The following is a description of a gene set: Mouse Gene Set: GOBP_REGULATION_OF_TRANSMEMBRANE_TRANSPORT Any process that modulates the frequency, rate or extent of the directed movement of a solute from one side of a membrane to the other. studied in species Mus musculus, and this is the list of marker genes: Fyn, Esr1, Lrrc26, Sphk2, Lhcgr, Prnp, Park7, Afg3l2, Rasa1, Asic2, Acsl6, Selenon, Stac, Dbi, Ffar4, Bin1, Dpp10, Akap7 (A kinase anchor protein 7), P2rx7, Gpc3, Oaz1, Ins2, Cnih2, Calm1, Sri, Ocln, Kcnj2, F2rl3, Grin2a, Grp, Rnasel, Grm6, Pou4f2, Gnb2, Mapk14, Ywhae, Kcnip2, Trdn, Trpc3, Cers1, G6pdx, Kcne3, Cyba, Homer1, Gsk3a, Rhoq (NCBI Gene Id 80836), Mrln, Kcnc2, Ptk2b, Mef2a, Mapk8ip2, Zfas1, Tmem74, Rgs7, Car2, Cacng7, Ucp2, Igf1, Kcnj6, Akap5, Ikbkb, Cacng3, Bpifa5, Nherf1, Kcnc1, Slc25a27, Nedd4, Chrm3, Fmr1, Tescl, Slc36a2, Trib3, Cd4, Sh2b2, Casq2, Fxyd4, Tlr9 (NCBI Gene Id 81897), Kcnab2, Plcg2, Scn4b, Coro1a, Braf, Fxyd5, Ywhah, Adipor2, Crhbp (corticotropin releasing hormone binding protein), Rem1, Agrn, Kcnn4, Fhl1, Atp4a, Prrt1 (proline-rich transmembrane protein 1), Camk2d, Rgs9, Actn2, Ctss, Enpp1, Cxcl9, Gpr39, P2rx1, Arg1, Nlgn1, Scn1b, Actb, Dysf, Atp4b, Gsto1, Hrc (NCBI Gene Id 15464), Ripk1, Cacnb4, Arg2, Septin2, Prkcd, Sumo1, Ppp3r1, Pim1, Drd2, Chd7, Cacnb2 (calcium channel, voltage-dependent, beta 2 subunit), Fgf15, Itln1 (NCBI Gene Id 640587), Wnk2, Ptpn3, Cacna1f, Casq1 (NCBI Gene Id 12372), Capn10, Edn1, Hspa2, Slc7a5, Shisa9 (NCBI Gene Id 72555), Wnk1, Bax, Adcyap1r1, Cemip, Cacng8, Abcb1b, Itgb3, Lep, Drd4, Ms4a2, Stim1, 1810037I17Rik, Plcb1, Shank1, Thbs1, Ffar1, Pea15a, Yes1, Ednra, Crh, Cox17, Cacng5, Repin1, Jsrp1, Slmap, Met, Nppa, Sorbs1, Gpr35, Kcnj16, Rap1a, Akt1, Fabp5, Edn3, Hap1, Lrrc52, Dmd, Ifng, Rps6kb1, Nol3, Jph3, Psen2, Cav1, Atp1b3, Arl6ip5, Tmc1, Ndufa4, Htt, Tgfb1, Kcnj10, Kcng4, Adrb1, Sestd1, Drd1, Cacna1c (NCBI Gene Id 619317), Irs1, Hamp2 (NCBI Gene Id 66438), Gnb5, Nedd4l, Clip3, Ahi1, Hk2, Cacng2, Fxyd6, Acsl5, Amigo1, Slc9a6, Epo, Erbb4, Akap6, Ywhaq, Chp1, Bmp4, Ntsr1, Cd19, Lcn2, C3, Ppp3cb, Ahr, Pik3cg, Oxsr1, Gimap5, Kel, F2r, Oprm1, Kcng1, Kcnj11, Taco1, Erfe, Thy1, Gip, Kcnmb1, Ubqln1, Gjc2, Arhgef11, Fxyd7, Tcaf1, Kcnn2 (NCBI Gene Id 14301), Sln, Kcns1, Ptpn22, Stxbp4, Tmem38a (transmembrane protein 38A), Prkca, Itgb1, Slc8a1, Cacng4, Myo5a (myosin VA), Ano6, Rgs4, Kcnj12, Ace, Stk39, Tcirg1, Dpp6, Cav3 (NCBI Gene Id 12391), Prss8 (NCBI Gene Id 97375), Fkbp1a, Appl1, Galr2, Ubr3, Arf1, Slc43a1, Cracr2a, Kcnj15, Nr4a3, Opn3, Abl1, Appl2, Pcsk9, Ppif, Kcnab3, Iscu, Gpd1l, Fkbp1b, Klf15, Il4 (NCBI Gene Id 16189), Atp2b4, Kcnip1, Kcnrg, Capn3, Gimap3, Rtn2, Atp2a1, Npsr1, Cbarp, Prkci, Rangrf, Bpifa1, P2ry6, Smim43, Cx3cl1, Mettl21c, Smim6, Tmc2, Osbpl8, Nlgn3, Arl6ip1, Upk3b, Kcnj3, Il1b, Stimate, Stxbp3, Rnf207, Gria1, Kcng3, Atg5, Abcc9, Cxcl11, Hpca, Pik3c2a, Atp1b2 (ATPase, Na+/K+ transporting, beta 2 polypeptide), Irs2, Tert, Tspan13, Ubash3b, Cacnb1, Prkd1, Pirt, Oaz3, P2rx4, Ldc1 (NCBI Gene Id 332942), Per2, Dlg1, Cacna2d1, Ms4a1, Kcnab1, Lime1, Ace2, Sirt6, Gal, Rgs2, Slc43a2, Erbb3, Lrrc55, Kcne2, Pln (NCBI Gene Id 18821), Cacna1d, Slc30a1, Ppp3r2, Kcnj1, Jph2, Gper1, Prkce, Tmem38b, Rasgrf1, Kcnip4, Crebl2 (cAMP responsive element binding protein-like 2), Shisa7 (NCBI Gene Id 232813), Grin2c, Nipsnap2, Oaz2, Akt2, Nfe2l2, Atp7a, Agtr1a, Trpc6, Diaph1, Calhm1, Slc38a1, Rasgrf2, Pdpk1 (3-phosphoinositide dependent protein kinase 1), Ank3, Spg7, Cnih3, Mtor, Ahcyl1, Ank2, Slc34a1, Myc, Osr1, Reln, Slc26a5, Scn5a, Gh, Phb2, Pid1, Slc1a2, Rapgef3, Kcnj5, Adipoq, Pth, Coa8, Inpp5k, Oga, Ppp3ca, Wnk4, Ptpn6, Cd63, Slc9a1, Bdkrb1, Cttnbp2nl, Aoc3, Stom, Cacnb3, Cltrn, Nlgn2, F2, Grb10, Calm3, Prkcb, Ak1, Gsg1l, Ehd3, Slc26a6, Scn3b, Vamp2, Aspscr1, Heph, Aplnr, Stac2, Fgf12, Akap9, Hamp, Tesc, Ahnak, Kcnj9 (potassium inwardly-rectifying channel, subfamily J, member 9), Cnksr3, Nr3c2, Oprk1, Bcl2, Vmp1, Ostn, Atp1a2, Abcb1a, Ryr2, Asph, Plp1, Strit1, Trpc1, Fxyd2, Ins1, Crbn, Mink1, Tmbim6, Cxcr3, Insr, Tgfb2, Ppp3cc, Lrrc38, Dhrs7c, Fgf13, Psen1, Stac3, C1qtnf12, Ptpn11, Kcnip3, Fcrl5, Scn2b, Vdac1, Kcnh2, Wnk3 (NCBI Gene Id 546388), Nherf2, Lyn, Plcg1, Pml, Azin2, Tmem168, C2cd5, Cftr (cystic fibrosis transmembrane conductance regulator), Pkd2 (polycystin 2, transient receptor potential cation channel), Fxyd3, Xcl1, Atp1b1, Kcnj8, Grin1, P2rx5, Mfn2, Cacng1, Slc17a8, Il13, Kcne1, Kcnj13, Acsl1, Scn10a, Kcne5, Ptger3, Agt, Cxcl10, Fxyd1, Ngf, Tnf, Dapk1, Nos1, Fbxo11, Atpsckmt, Grk2, Fgf21 (NCBI Gene Id 56636), Clec4b1, Grin2d, Gopc, G6pd2, Bak1, Pde4d, Kcnj14, Calm2, Kcns2, Azin1, Commd1, Kcnq1, Cacng6, Mcub, Grin2b, Mmp9, Kcnj4, Flna, Acacb, Adrb2, Gstm7, Snca (NCBI Gene Id 20617), Fgf14, C1qtnf2, Slc31a2, Snta1, Neto1, Wwp2, Stim2, Sco1 (NCBI Gene Id 67104)